The following is a description of a gene set: part of: Signaling by NTRK2 (TRKB) Reactome Pathway: Activated NTRK2 signals through CDK5 species: Homo sapiens CDK5, in complex with its activator CDK5R1 (p35), binds to BDNF-activated NTRK2 (TRKB). NTRK2 promotes CDK5 catalytic activity by phosphorylating CDK5 at tyrosine residue Y15, although CDK5 can also be phosphorylated at Y15 independently of NTRK2. CDK5 phosphorylates serine residue S479 of NTRK2 (corresponds to S478 in mouse and rat). Phosphorylation of NTRK2 at S479 is needed for BDNF-triggered dendritic growth, hippocampal long-term potentiation (LTP) and spatial memory. These processes involve NTRK2-mediated activation of RHO GTPases RAC1 and possibly CDC42. In cultured isolated neurons, phosphorylation at S479 affects localization of NTRK2, but this does not appear to be the case in vivo.<p>CDK5-mediated phosphorylation of NTRK2 was suggested to influence the level of AKT activity, downstream mTOR signaling and DLG4 (PSD-95) expression, but further elucidation is needed.<p>Signaling by TRKB and CDK5 plays a role in inflammation induced hypersensitivity to heat-triggered pain in rats., and this is the list of marker genes: NTRK2, TIAM1, CDK5, BDNF, CDK5R1 (NCBI Gene Id 8851), RAC1